Given this list of marker genes Vps4a, Nppc, Ms4a2, Fcer1a, Cacna1d, Rab2b, Gab2 (NCBI Gene Id 14389), Cdk5, Kcnb1, Pdcd6ip, Pla2g3, Atp13a2, Vps4b, Lamp1, Doc2b, Itgb2l, Zp3, Il13, Snx4, Cacna1i, Exoc2, Rab3d, Fcer1g, Sdc1, Cacna1h (NCBI Gene Id 58226), Cadps2, Sytl4, Rab27a, Sdc4 (NCBI Gene Id 99320), Myo5b, Clasp2, Smpd3, Itgam, Septin5, Stam, Snca, Stxbp2, Rph3al, Cd177 (CD177 antigen), Nppa, Stx1a, Nlgn1, Rab15, Ncs1, Gata2, Fga, Ap1g1, Il4ra, Tsg101, Hgs, Syt10, Il4, Hyal3, Crhr1 (NCBI Gene Id 12921), Dnm1l (NCBI Gene Id 74006), Cadps, S100a10, Lypd11, Fgg, Bcl2l1, Cacna1g, Stxbp5, Vamp8, Fgb, Doc2g, Cd160, Pla2g6, Chmp2a, Syt4, Snf8, Rab5a, Slc4a8, Pld2, Stxbp1, Rab9, Rab7, Arf1, Cdk5r2, Gata1, Rab3a, Scamp5, Syt1, Rab27b, Lypd10, Ptafr, Vsnl1 (NCBI Gene Id 26950), Adora2b, Adora3, Syt7, Stx4a, Exph5, Unc13b, Rph3a, F2rl1, Prkca, Unc13d, Sdcbp, Cftr, Anxa2, Sphk2, Doc2a, Rufy4, Itgb2, Fgr, Syk, Syt9, Clasp1, here is a description of the gene set: Mouse Gene Set: GOBP_POSITIVE_REGULATION_OF_EXOCYTOSIS species: Mus musculus Any process that activates or increases the frequency, rate or extent of exocytosis.